Given this list of marker genes Slc4a4, Ddit4, Prkag1, Pde9a, Zbtb7a, Slc4a1, Eif6, App, Nupr1, Mlx, Eno1, Trim63, Zbtb20, Entpd1, Upb1, Tigar, Pklr, Rptor, Hkdc1, Pgk2, Igf1, Aldoart1, Nudt4, Urah, Foxk1, Hif1a, Gapdhrt2, Gpd1, Mlxipl, Prkaa1, Ier3, Pgk1, Sirt6, Ada, Xdh, Tkfc, Pde4c, Pkm, Nt5c3, Itpa, Pde4d, Nt5c2, Pfkl, Aldoc, Nt5c1b, Dpys, Cbfa2t3, Git1, Pde2a, Ogt, Ppara, Eno1b, Uchl1, Pgam2, Galk1, Urad, Nudt11, Nudt9, Prkaca, Ins2, Myog, Arl2, Slc29a1, Mfsd8, Slc2a6, P2rx7, Src, Nt5c1a, Mlst8, Pde10a, Uox, Mtor, Pde1a, Gapdhs, Fbp1, Nudt3, Gda, Hk2 (hexokinase 2), Esrrb, Trex1, Gale, Aldoa, Kat2b, Pfkfb2, Upp2, Hk3, Gapdh, Nt5c, Prkaa2, Pde7a, Aldob, Dpyd, Entpd4b, Entpd7, Aldoart2, Pgam1, Hprt1, Ncor1, Jmjd8 (jumonji domain containing 8), Prkag2, Col6a1, Pde8a, Upp1, Ins1, Insr, Lipa, Prkag3, Eno4, Bcl2l13, Cda (cytidine deaminase), Foxk2, Htr2a, Ep300, Pfkfb3, Mtch2, Pde4a, Gck, Entpd4, Nudt18, Gpi1, Entpd5, Mpi, Pnp, Prxl2c, Psen1, Ppp2ca (NCBI Gene Id 97777), Myc, Dhtkd1, Actn3, Galt, Pfkp, Ampd3, Ppargc1a, Ifng, Hk1, Eno3, Hint1, Nudt10, Gapdhrt, Gmpr2, Pfkfb1, Arnt, Adpgk, Eno2, Khk, Ogdh, Pde5a, Flcn, Hdac4, Sik2, Tpi1, Pde7b, Pfkm, Bpgm, Pde8b, Stat3, Il3, Ucp2, Nt5e, Fkrp, Enpp1, here is a description of the gene set: studied in species Mus musculus The chemical reactions and pathways resulting in the breakdown of a ribonucleotide, a compound consisting of ribonucleoside (a base linked to a ribose sugar) esterified with a phosphate group at either the 3' or 5'-hydroxyl group of the sugar. Mouse Gene Set: GOBP_RIBONUCLEOTIDE_CATABOLIC_PROCESS